The following is a description of a gene set: Mouse Gene Set: chr6E2 species: Mus musculus, and this is the list of marker genes: Gm6749, Gm32858, Gm29781, Gm4605, Edem1, Arl8b, Bhlhe40, 0610040F04Rik